Given this list of marker genes PCK1, GOT1, CFH, RGN, HAO1, KYNU (kynureninase), FABP1, RARRES1, TDO2, EGFR, CTRC, CYP4F2, C4BPA, MAPKAPK2 (MAPK activated protein kinase 2), RGS16, HSD11B1, ZC2HC1C, SFTPD, APOC4, CYP2F1, CYP2E1, OTC (NCBI Gene Id 5009), FABP2, PNLIPRP1, BHMT, SLC25A22, G0S2, NR1H3, ETNK2, ELANE, HBP1, DCT, G6PC1, ELOVL5, IGF1, MCM10, REPS1, TNNC2, ORM2, REG1A, MAT1A, GHR, IGFBP2, ORM1, MTARC1, ACSL1, ABCD3, SLC27A2, IL1RAP, BAAT, CFHR1, ALAD, OAT (ornithine aminotransferase), TRPV2, CYP7B1, NETO2, ADIPOR2, AASS, PXMP2, CPOX, HPD, EPHX2, ME1, HAL, here is a description of the gene set: from publication Lee JS, Chu IS, Mikaelyan A, Calvisi DF, Heo J, Reddy JK, Thorgeirsson SS (PMID 15565109) Genes down-regulated in hepatocellular carcinoma (HCC) from MYC and E2F1 double transgenic mice. Genetically modified mice have been extensively used for analyzing the molecular events that occur during tumor development. In many, if not all, cases, however, it is uncertain to what extent the mouse models reproduce features observed in the corresponding human conditions. This is due largely to lack of precise methods for direct and comprehensive comparison at the molecular level of the mouse and human tumors. Here we use global gene expression patterns of 68 hepatocellular carcinomas (HCCs) from seven different mouse models and 91 human HCCs from predefined subclasses to obtain direct comparison of the molecular features of mouse and human HCCs. Gene expression patterns in HCCs from Myc, E2f1 and Myc E2f1 transgenic mice were most similar to those of the better survival group of human HCCs, whereas the expression patterns in HCCs from Myc Tgfa transgenic mice and in diethylnitrosamine-induced mouse HCCs were most similar to those of the poorer survival group of human HCCs. Gene expression patterns in HCCs from Acox1(-/-) mice and in ciprofibrate-induced HCCs were least similar to those observed in human HCCs. We conclude that our approach can effectively identify appropriate mouse models to study human cancers. Human Gene Set: LEE_LIVER_CANCER_MYC_E2F1_DN species: Homo sapiens